The following is a description of a gene set: species: Homo sapiens Genes containing one or more binding sites for (SAFB2) in their promoter regions (TSS -1000,+100 bp) as identified by GTRD version 20.06 ChIP-seq harmonization. from publication Yevshin I, Sharipov R, Kolmykov S, Kondrakhin Y, Kolpakov F (PMID 30445619) Human Gene Set: SAFB2_TARGET_GENES, and this is the list of marker genes: LINC02569, TRNAU1AP, HDHD5-AS1, CPNE1, FOXRED1, MED15, ENSG00000207751, GVQW3, EDF1, DXO, MYLIP, TEDC2, ZNF587B, CUL7, MT-ATP6, AHCYL1, SNAP29, MIR4757 (microRNA 4757), SNHG12, C22orf39, SAR1A, MTDH, HEATR3, HADH, PFKFB3, KLHL18, SERPINB9, PTCH2, FRMD8, HNRNPAB, RNF138, MIR17HG, TRIO, TRIM65, ILF3, ANKRD23, DNAJC9-AS1, ATR, BICDL1, TMEM106C, TTC23L, IGLV6-57, CDK5RAP1, IGLV9-49, ZCWPW1, SLC12A9-AS1, MT-TD, ACKR2, FICD, PGAM5, MPC1-DT, ITGAV, ACTB (actin beta), UBE2D1, MARCHF4, TEAD3, CRKL, MT-TS1, ABHD11, PSMD5, B3GNTL1, ZFP69B, MCFD2, NPC2, BCAT2, ST7, FBXO21, CASP2, SLC9A1, CRELD2, RNA5SP493, SLC25A1, ZDHHC8, PHAX, TAP2, MBD4 (NCBI Gene Id 8930), MPC1, MIR5188, FKBP15, SNRPC (NCBI Gene Id 6631), TMX4, DNAJC10, TIMM17A, MAP3K9, TSEN2, RNA5SP473 (NCBI Gene Id 106479017), UFL1, ZNF764, LZIC, RPS15, STX10, TOR1A, CYB561D1, KTI12, CCNDBP1, RTF2, ZNF197, WDR37 (NCBI Gene Id 22884), C6orf47, ASH2LP4, CYREN, SLC25A16, CSNK1D, MAK16, GOLT1A, SLC31A1, ZNF628-DT, KRT18P5, SQOR, TAMM41, CHCHD2, TSPAN17, ANK1, TXNDC5, EFCAB10, EMC1, NSMCE3, MRM2, KCTD9P5, MARCHF3, IPP, LAMP3, CREB1, DLG4, IST1, FAM32DP, FLAD1, ERGIC2, RASSF4, TMC3-AS1, S100A16, GET1, ADRM1, EPRS1, TLR5, NDUFA11, SNORD43, MIEF2, VWA7, BRD9, MUTYH, ZNF584, FAM53C, TSR1, SON, TEX41, FAM120B, CLASP1 (cytoplasmic linker associated protein 1), REST, HSPA1B, FAM185A, NPEPPSP2, MYD88, VEZT, TENT5B, MT-TK, ALAD, CSKMT (citrate synthase lysine methyltransferase), RAD50, TOMM34, TRIP11, RNU6-75P, NSDHL, KMT2A, CLASP1-AS1, EVI5L, ZMAT3, LINC01849, MALAT1, GAN, ZNF652, IFT20 (intraflagellar transport 20), KLHL12, EIF4EBP2, ERCC6, CRLS1, TMPRSS9, SUCO, ZSWIM9, SLC9B1, CLTC, IGLV10-67, GNAZ, FAHD1, GDF5, IQSEC1, MED31, MTFR1L, NOC4L, CREBRF, PFKFB4, GOLGA7, LRWD1, ZNF217, SLX9, MINDY2, CCNYL1, EFCAB2 (EF-hand calcium binding domain 2), ZNF766, ZNF253, ABCA7, PPM1F, CIAO1, DGCR8, GTF3C1, CYTH2, IGLV7-46, PRR7, TNFAIP1, ABCF1, CCT6P1, FAM111A-DT, CACTIN, SNAI3-AS1, MT-CO1, PHAF1, ZC3H7A, LINC02482, IFT122, WDR24, TMEM177, EPS15, R3HCC1, VMAC, TRIM26, LINC01194, UBE2J1, RIPOR3 (RIPOR family member 3), NMU, CNGA4, LINC01410, ZNF408, TMX4-AS1, RN7SL188P, SLC29A1, SMPD4P1 (sphingomyelin phosphodiesterase 4 pseudogene 1), ALKBH6, LINC00701, RNASET2, MT-TW, OSER1, ENSG00000281863, ARPC1A, APRT, ZNF232-AS1, HERPUD2, WIPI1, MT-TA, ZNF232, SORBS3, RPL31, RANBP2, KIAA1328, MFSD11, UBXN2B, CLK3, PDIA4, ASCC1, SRPRA, P4HA2, TCTN1, ADPRS, STK19, MCL1, RCCD1, USP2-AS1, ZNF3, MIR3180-4, ZNF593, PABPN1, LUC7L, HMGA1 (high mobility group AT-hook 1), NPC1, MFN2 (NCBI Gene Id 9927), ALG12, SPOPL, MST1P2, UBE2I, ATP11B, PDCL3, CS, DQX1, ENHO, PRPS1, SPAG4, RFT1, H3-3A, ASCC2 (NCBI Gene Id 84164), SUMO1 (small ubiquitin like modifier 1), FGD4, FTL, VAC14, EIF4BP2, IGLV2-11, MTCO3P12, MRPL40, MIR3190, PHKG2, NAP1L4, TPST1, CCDC137, RNASEH2C, CIRBP, DHTKD1 (dehydrogenase E1 and transketolase domain containing 1), MINDY2-DT, HERPUD1 (homocysteine inducible ER protein with ubiquitin like domain 1), SMG1-DT, TSC22D2, SNORA16A, TMEM18, ZNF557, CHP1, FZD9, CETN2, MT-RNR2, APMAP, NMNAT1, ZNF224, SLC12A9, KCTD21-AS1, ZSCAN20, ASL, MTND5P11, OXLD1, RPL13, MAP4, STARD9, GLUL, DEAF1, HAUS2, MT-TP, ENSG00000246308, GALNT18, ANKRD12, UBXN4, PNPLA8, TMEM127, IER2, SH2B1, SDCCAG8, APOA1-AS, ENSG00000249236, SNORD68, CNPY2-AS1, LIPT2, RNF19B, LIMS1, CUTA, RNU4ATAC, TPK1, RIPK1, HDAC4, ZNRD2-DT, CHIC2, HNRNPH1, ZNF497, PFKFB3-AS1, UBA52, ENSG00000236846, FBXO24, SMC1A, FAM86C2P, KIAA0319L, ZNF324, ATP5IF1, SNORA57, MRNIP, SLC7A4, RAET1K, ZKSCAN5, POLR1E, SLC38A10, LCN8, TANGO2, TK2, IKBKG, IL5 (NCBI Gene Id 3567), USP49, AGAP3, MIR3181, NCKAP1, GAK, TBC1D5, ABL1, LINC00205, CHMP4B, PCGF1, PMS2P3, FER, NDUFV2-AS1, PHF14, RUBCN, TRIM21, USP45, DDX42, CRACR2A, RNU6-1315P, TPTEP1, JPT1, SMIM29, SDF2L1, MRPS23, ELP6 (NCBI Gene Id 54859), FBF1, RTL10, MT-CO2, TRMT6, AIF1L, PRP4K, NFIC, AMZ2, MIR5695, DSN1, ITSN1, SCN5A, NUDT1, STARD5, CBFA2T2, UFD1-AS1, ANAPC16, ALG1, IL10RA, ASAH2B, SYCE2, ETFBKMT, MRPS9, GCA, PCNT (pericentrin), TMEM52, RBAK, CCDC138, MEN1, TMEM41A, CFL1P1, NQO2-AS1, C17orf100, CEP350, CNOT3 (CCR4-NOT transcription complex subunit 3), SRSF2, ZNRD2, ENSG00000267698 (NCBI Gene Id 101927572), TBC1D32, NUBPL-DT, GATAD2A, NT5C, ZNF446, VPS9D1 (VPS9 domain containing 1), ANKRD39, CCDC106, KIAA1586, HBP1, CHD8, TYW3, GGA2, ARMC10, WDTC1, LAP3, ELOVL7, MT-RNR1, RSPH14, FAM111A, UBE2Q1, HMOX2, KDM5B, UAP1, GART, PHF1, NRSN2, ZNF680, ALG8, NMRAL1, FBXO4, SGSM2, AHCTF1, ZNF628, MKLN1-AS, ZNF621, ZNF652-AS1, OR5G4P, PCTP, FSCN1, SNHG15, USP42, UFL1-AS1, PARS2, HERPUD2-AS1, CDK5RAP3, FAM83D, MAD1L1, INO80, HMGB1P45, ACO1, RPN2, PARK7, LUC7L2, MRPL9, MT-ATP8, ZNF212, RHEB, WDR70, ZNF845, MIR301B, FYTTD1, MT-TQ, RNU6-97P, ACIN1, LIPT2-AS1, DDX51 (NCBI Gene Id 317781), EMC3, ACAP2, HAUS4, DENND1B, AAMP, SMG1, ODAD1, POLE3, SPEF1, SECTM1, COMT, MTMR2, PPIL4, ALKBH4, VCPIP1, MAPDA, SEC13, SPNS1, KICS2, FYCO1 (FYVE and coiled-coil domain autophagy adaptor 1), SFR1 (NCBI Gene Id 119392), MIR7155, TPRG1L, RNU6-1284P, THAP12, LIG1 (DNA ligase 1), USP48, DENR, CD55, GGCX, CERS5, ICAM5, TMEM184C-DT, CSMD1, FGFR4, TMEM139-AS1, DGCR6L, PCBP1-AS1, ACADS, DDAH2, NBPF1, LINC00662, TNRC6C, RHBDD1, ISCA2, PGAP2, USP2, CHD9, ZNF341-AS1, LINC03011, ANKFY1, TMEM198, OAZ3 (ornithine decarboxylase antizyme 3), SNRPB, C1QTNF3, FHIP1B, DDX41, FBXL13, ZNF580, MCM8, CDC37, C11orf54, ZFHX2, LRRN3, GFER, PKD1L2, CPLANE2, CDC25C, TMEM80, NSUN5, RNU6-628P, BTBD10, CEP250, ZNF432, GNB1L, RPL3, ZNF324B, C17orf75, GARNL3, TMEM70, NUP98, SMIM10L1, TMEM14C, DCTN5, POLD1, TOP1, KIF17, NUS1, PAXBP1-AS1, ACOX3, TFPI, OR2AJ1, FBXL9P, ENSG00000248783, TIAL1, TAS1R1, CLN5, PARP12, GK5, RAD51AP2, KATNIP, TMEM184C, ARF4P4, SDR39U1 (NCBI Gene Id 56948), RBM12, VAPA, TNFRSF10B (NCBI Gene Id 8795), MKLN1, EXD1, NUBPL, C21orf58, PROCA1, GID8, IFNAR2, VAMP8 (NCBI Gene Id 8673), PIAS4, HIGD1A, ATAD1 (ATPase family AAA domain containing 1), RNF216, BMP2K, MOSPD3, GXYLT1, STRADA, TTC23L-AS1, ZFP1, FCF1P7, CDPF1 (NCBI Gene Id 150383), SRPK2, KCTD7, TNIP2, L3MBTL3, NCDN, RIBC1, RBBP9, POLD2, PAPPA-AS1, HAS3, CHROMR, KDM7A-DT, CASQ2, SEC23B, CALU, C11orf98, TPGS2, H3-3A-DT, SCRN2, PDF, MT-TF, ACAT2, NUP214, LINC00620, LRRC57, MT-TN, TAF12, CRYZ, DIP2A, DPRXP3, APOL2, MAP3K9-DT, MAPK8, PCK1, ASCC3, TBL2, ILF3-DT, HGH1, LRCH4, ARVCF (ARVCF delta catenin family member), KCNMB3P1, ZNF487, GPD1L, SPOUT1, TUBGCP5, TMEM135, HMG20A, CROCCP2, HOOK2, SNX19, ARHGAP26, DIDO1, HDHD2, EIF4G2, MCM8-AS1, MRPS25, TMEM63A, STK35, APEX1, AATF, CLK1, SLC39A11, LINC01547, SPOPL-DT, TBC1D16, G6PD, TOB2P1, RPL23AP77, NOCT, RABGGTA, SORT1, WDTC1-DT, UHMK1, PEAK1, DLL1, FANCA, HIRA, YJU2B, XPO1, P2RX6, TAF12-DT, FMC1, TMEM120A, CREBZF, NOL9, PDCD6P1, TUBB4B, TIMM22, MKNK1, HAGH, TPD52L2 (TPD52 like 2), MRNIP-DT, MRTO4, KDM7A, TMEM97, MAFB, IDI1, HEXB, OSGEP, SNAPC2, CYLD, LINC02987, MVD, DDX18, PLEKHG4, TMEM208, CLTB, ACTR2, SRSF3, MEPCE, KIF9, SYNJ1, PPP2R5D, HINFP, CRISPLD2, CACFD1, MT-TC, PPIB, COPS9, FAHD2A, UBE2S, FMC1-LUC7L2, TMEM175, ATF3, ZNF84-DT, RBAK-RBAKDN, LCAT, CMBL, XYLB, TMEM14A, OR7E24, CCDC47, TCTE1, ANKRD28, CDC6, TOP3B (DNA topoisomerase III beta), EXOSC6, TOR2A, ZNF821, UBC, PNKD, TMEM18-DT, MRPL34, MYOSLID-AS1, RALGAPB, GSS, SEPTIN5, PALB2, JUNB (JunB proto-oncogene, AP-1 transcription factor subunit), TOE1, ZNF131, RPS13, PTS, TMEM44-AS1, AP4M1, PRKCZ, ARID2, ARHGEF19, CHPF, POGZ, CPQ, DNAJB4, EGLN3, PPIL2, SCARF2, MT-TY, RBM15B (NCBI Gene Id 29890), TRIP13, LBX2, ZNF84, ZNF581, POLD3, AAGAB, MCM7, SOCS2P2, RSRC1, HNRNPU, IFT172, KCNK5, PKD1P6, RAB43, TEP1, NQO2, HDAC4-AS1, SMURF2, CCDC88B